The following is a description of a gene set: from publication Chen Y, Wang X (PMID 31504780) Genes predicted to be targets of miRBase v22 microRNA hsa-miR-10396b-5p in miRDB v6.0 with MirTarget v4 prediction scores > 80 (high confidence targets). Human Gene Set: MIR10396B_5P studied in species Homo sapiens, and this is the list of marker genes: SCRT1, TNFRSF8, ACSL3, MDGA1, DPP9, SIRT6, NRARP, STPG1, TGFB1 (NCBI Gene Id 7040, transforming growth factor beta 1), NFIX, ABO, DUOXA2, STK11, ESPN, MIA2, FKBP8, HOXC10, SLC29A3, AP5Z1